Given this list of marker genes RAB27A, CLPTM1, NUP37, LUC7L, AGPS, EPAS1, GLRX, CENPP, PRKX, GFM1, PLK4, RRM2, GINS4, PPP3CA, NCBP2, CDCA8, CDC25C, MFSD1, LILRB4, PPP4C, MACROH2A1, SLAMF1, CDCA2, PIH1D1, MELK, FIGNL1, EIF3C, MATN2, BLVRA, HSD17B12, SERPINB9, MFAP3, CEP55, TOMM6, EDEM3, RAB11FIP4, PSMA7, H2AC25, DHX29, H4C4, CENPE, RAD51AP1, LRR1, COX7A1, IDH3A (NCBI Gene Id 3419), FHIP1B, LSM4 (NCBI Gene Id 25804), PSMA2, TEX9, NDUFB8, CALM3, F2RL2, ZMPSTE24, ECH1, CETN2 (centrin 2), RAD51, GOPC, COX4I1, KIF22, CCDC34, POLR2K, MCM7, SMC2, CXCR6, ATP6V1A, GAS2L3, H2BC1, HAVCR2, BUB1, CIT, LGALS1, KNTC1, LRRC41, DPCD, EPHA3, CTSD, KIF18A, INSL6, SF3B5, MPND, IL2RA, ITGB2, NEPRO, TOP2A, MTX1, PSMD13, TSPAN2, SPN, CDC45, NPC1, LAMC1, PACSIN2, ZMYND11, TEX15, MYO1G, ADGRE5, MDM1, GABARAPL2, HSPA13, BUB1B, TUBB2A, EFTUD2, HASPIN, CHD7, UBE2T, SSR1, KIF20B, KIF4A, ST3GAL4, NCAPG, PRDM1, VPS45, SLC2A3, PSMD2, GSS, ADD1, SHCBP1, BLMH, RAD54L, KIF23, SERINC3, ASPM, DNAJB6, KLRC1, PYCARD, TRAPPC1, NXT2, TBCB, GHITM, PSMB7, SYNGR2, GALK2, DTL, PTPN12, CINP, CENPF, DAPK2, TNFSF10, GGH, ELOF1, EPRS1, HSPA5, TRIP13, KNL1, SSR3, ATP5F1A, DYNC1I2, MED21, GBP3, SDHD, MT2A, RMDN2, LYAR, APPL1, CRYBG1, NDC80, EGLN1, PDCL, PRC1, CFL1, SGO1, DPM3, RRM1, LIN54, KIF15, CDK1, KLHL28, PPP1CA, SGO2, RUNX1, CDK2, PGK1, NDUFA9, RBM8A, MCM8, PDIA6, CDC37, POLR3K, RPS6KA1, SPDL1, H2BC4, PGM2L1, CRIP1, PBK, MAP2K3, here is a description of the gene set: species: Homo sapiens Genes up-regulated in B lymphocytes: naïve versus memory. Memory B cells play essential roles in the maintenance of long-term immunity and may be important in the pathogenesis of autoimmune disease, but how these cells are distinguished from their naïve precursors is poorly understood. To address this, it would be important to understand how gene expression differs between memory and naive B cells in order to elucidate memory-specific functions. Using model systems that help overcome the lack of murine memory-specific markers and the low frequency of antigen-specific memory and naïve cells, we undertook a global comparison of gene expression between memory B cells and their naive precursors. 1st generation screen: These data represent our first generation comparison of gene expression between murine naïve and memory splenic B cells. Naïve NP-binding splenic B cells were FACS purified from unimmunized mVh186.2 transgenic Balb/c mice. Memory B cells were generated by immunizing mVh186.2 transgenic Balb/c mice with 2 doses of NP-CGG in alum delivered i.p. 6 weeks apart. After a minimum of 12-weeks rest, NP-binding splenic B cells were isolated by FACS. Total RNA was extracted, cRNA synthesized and labeled and hybridized to Affymetrix mouse 430 2.0 chips. 2nd generation screen: These data represent our second generation comparison of gene expression between murine naïve and memory splenic B cells. Naïve NP-binding AA4.1neg splenic B cells were FACS purified from unimmunized mVh186.2 transgenic Jk KO Balb/c mice. Memory B cells were generated from these naive precursors after adoptive transfer into recipients that mount poor endogenous NP-responses. 12-weeks post i.p. immunization with NP-CGG in alum, NP-specific splenic memory B cells were isolated by FACS. Total RNA was extracted, cRNA synthesized and labeled and hybridized to Affymetrix mouse 430 2.0 chips. Memory/Naïve comparison data linked below as Supplementary files. from publication Tomayko MM, Anderson SM, Brayton CE, Sadanand S, Steinel NC, Behrens TW, Shlomchik MJ (PMID 18566367) Human Gene Set: GSE11386_NAIVE_VS_MEMORY_BCELL_UP